The following is a description of a gene set: from publication Chen Y, Wang X (PMID 31504780) Human Gene Set: MIR569 Genes predicted to be targets of miRBase v22 microRNA hsa-miR-569 in miRDB v6.0 with MirTarget v4 prediction scores > 80 (high confidence targets). studied in species Homo sapiens, and this is the list of marker genes: SPRED2, SMG1, ZFP90, SNX4, SMIM9, ELAVL4, ABTB2, TP53INP1, FGF9, SLC39A12, TLE4, ACSL6, LRRC8B, ATG7, CNOT7, DEPTOR, MELTF, RASGEF1A, WWP2, MPDZ, PALS1, MOSPD1, SYT15, TAOK1, TMEM267 (NCBI Gene Id 64417), GMFB (glia maturation factor beta), VEGFA, RBM24, LPAR6, MAP4, CFAP58, PCDHA9, KLHL8, AQP4, ZNF793, STX17, UCHL3, RSBN1 (NCBI Gene Id 54665), CLDN1, LMNB1, RAB39B, KIAA1549, E2F5, PCDH17, CP, THAP10, RUNX1T1, SMARCA5, TTC3, NDUFA8, PNPLA8, VTI1A, ZFAND6, ZNF407, GPR82, G3BP2, CNGA3, FOS, PDSS2, TBC1D15, SV2C, CLCN3, PTPRZ1, NEBL, CDK2AP1, TCAIM, SLC39A10, SLC18A2, DNAJC13, DCP1A, BARD1, CCPG1, LRRTM3 (NCBI Gene Id 347731), SLC35A3 (solute carrier family 35 member A3), MFSD6, GAB1, SMARCA4